Given this list of marker genes AXIN1, LHX5, TBX6, GJB1, ISL1, HDAC3, HDAC9, CTBP2, HAND1, HDAC10, ETS1, TLX2, CDH1, HOXA1, FZD3, COL2A1, DVL1, GFAP, PHOX2B, RBPJ, BMP7, OLIG3, PAX3, MIA, CDH7 (NCBI Gene Id 1005), HDAC8, FGFR1, TWIST1, ZIC1, BMP4, FGF19, MBP, LHX1, CTNNB1, SOX10, MPZ, LHX2, PRTG, TFAP2A, DMBX1, HDAC2, CDH6, MSX1 (NCBI Gene Id 4487), ID1, DLX5, MYB, OLIG2, HDAC7, GBX2, WNT8A, SMAD1, HDAC6, ASCL1, TFAP2B (NCBI Gene Id 7021), MSX2, HOXB1, MITF, AXIN2, TCF7L1, FOXD3, DLL3, HDAC5, FGF2, WNT3A, WNT1, RHOB, DVL2, NOTCH3, ZIC5, SNAI2, FGF8 (fibroblast growth factor 8), HDAC11, SOX5, NFKB1, FGFR2, HDAC4, DLL4, OLIG1, HES1, PAX7 (NCBI Gene Id 5081), HEY2, GSK3B, CDH2, HDAC1, NOTCH1, FGFR3, DVL3, PMP22, SNAI1, HES5, DCT, NOTCH4, NOTCH2, NEUROG1, COL11A2, SOX9, TCF4, ITGB1, DLL1, NFKB2, MYC, here is a description of the gene set: Human Gene Set: WP_NEURAL_CREST_DIFFERENTIATION studied in species Homo sapiens Neural crest differentiation